The following is a description of a gene set: Human Gene Set: GSE17974_2.5H_VS_72H_IL4_AND_ANTI_IL12_ACT_CD4_TCELL_DN Genes down-regulated in comparison of CD4 T cells treated with IL4 and anti-IL12 at 2 h versus those at 72 h. species: Homo sapiens from publication Elo LL, Järvenpää H, Tuomela S, Raghav S, Ahlfors H, Laurila K, Gupta B, Lund RJ, Tahvanainen J, Hawkins RD, Oresic M, Lähdesmäki H, Rasool O, Rao KV, Aittokallio T, Lahesmaa R (PMID 20620947) The aim of this dataset was to study in detail the transcription kinetics initiated by cytokine IL-4 in early differentiation of Th2 cells., and this is the list of marker genes: LINC00029, DHFR, BHLHE40, ZSCAN22, RAB13, MTA3, CEP57L1, NSMCE2, ALKBH6, TXN, PSMD4, SQLE, CUEDC2, MTFP1, NOPCHAP1, ITGB2, SFXN1, EIF4E3, GEMIN7 (gem nuclear organelle associated protein 7), SLC66A3, LINC01924, TXNIP, CDC25B, ASIC5, TIAM1-AS1, ZSCAN30, HSDL2, CDK5, ZEB1-AS1, NOA1, MCRIP2, UGP2, HIRIP3, CD9, SFN, LETMD1, ANXA4, ADK, CAPN12, INTS2 (NCBI Gene Id 86656), CMAS, TRIQK (triple QxxK/R motif containing), MAP4K1, PARN, CRYL1, LRRC32, BRI3BP, TCEA1, DHCR24, RNF144A, FAM241B, CAPG, HMGN4, TCEA3, UHRF1, HOMER2, GINS3, TMEFF1, IL10RB, MAP3K21, PIH1D1, NLRX1, PTPN18, CAMK2G, MAGEF1, PSMB10, TCEAL3, DPAGT1, BEX3, SERPINB6, MPV17, GSDMB, DLG3, OXSM, ABHD10, COMMD7, ZNF775, UQCRC1, MGAT1, IL32 (NCBI Gene Id 9235), RHEBL1 (RHEB like 1), MTMR4, CD5, ITM2C, GOLPH3L, KCNN4, DHX58, DGKH, NUP107, KYAT1, S100A4, RMND1 (required for meiotic nuclear division 1 homolog), MICU1, GPANK1, ING1, GNGT2, ISCA2, LAMTOR4, GUSB, NUDT2, SERPINH1, ACP6, RAB6A, C12orf75, BATF3, ZNF558, PRPSAP1, DHX32, FUCA2, TXN2 (NCBI Gene Id 25828), RHOC, LMNB1, ZNF575, C4orf3, SYNE4, POU2F1, ASCC1, LSM2, SRI, RECQL, ETHE1, HSD17B8 (hydroxysteroid 17-beta dehydrogenase 8), RAD51C, DRAM2, CYP51A1, VSIG10L, FLOT2, MGST3, HPDL, CEP41, CSRP2, TMEM273, JAKMIP2, TNFRSF4, FSD1, HPS3, STYXL1, PKM, DBI, MTIF2, DARS1, ARF5, POLD3, SARS2, EIF2AK1, GTDC1, CUTA, STXBP1 (syntaxin binding protein 1), TMEM218, CDK2, SRD5A1, UNC45A (unc-45 myosin chaperone A), BUB3, PRIMPOL, NUP85, NOL3, STMN1, PIP4K2B, EMILIN2, STOML2, RPS6KA1, SMCO4, CRADD, PDP2, NSF, CPNE2 (copine 2), PARVB, UCK2, DLG5, POLQ, S100A6, ACAD9 (acyl-CoA dehydrogenase family member 9), BMPR1A, CLNS1A, SIGLEC17P, CEP152, RDX, ACADVL, PHPT1, PTAR1, SBF2-AS1, TMEM97, PINLYP, INPP1, MRPL48, CS, B3GNTL1, PARP2, RAB20, SORD (NCBI Gene Id 6652), EME1, ANKRD39, RCCD1, PSMB8, MAD2L2, ADD1